Given this list of marker genes Arl5a, Arl5c, Rab6b, Arl5b, Rab6a, here is a description of the gene set: Mouse Gene Set: GOBP_PROTEIN_LOCALIZATION_TO_GOLGI_MEMBRANE species: Mus musculus A process in which a protein is transported to, or maintained in, a location within a Golgi membrane.